The following is a description of a gene set: Human Gene Set: MIR6504_5P species: Homo sapiens Genes predicted to be targets of miRBase v22 microRNA hsa-miR-6504-5p in miRDB v6.0 with MirTarget v4 prediction scores > 80 (high confidence targets). from publication Chen Y, Wang X (PMID 31504780), and this is the list of marker genes: ADD1, AAK1, MSRB2, ZNF12, AP1M1, SLC36A1, TXNIP (thioredoxin interacting protein), FYCO1, ANKRD36, LEMD2, TRAPPC3L, LZTS1, CRIM1, DHCR24, AREL1, HNMT, GALNT10, CNOT10, SLC4A8, EIF5, EDAR, PIP4K2B, PRDM10, BAG4, ATP1B4, CCDC186, PRDM4, CNN3, PTPRT, MRPL52, HEMK1 (HemK methyltransferase family member 1), ZNF850, ZNF782, MECP2, RHOJ, SPRED2, WASHC4, HMOX2, JOSD1, PAX5, NECTIN4, SLC26A1, SAV1, NR4A3, CIMAP2, SLC26A9, PRR15L, PCDH20, TBL1X, CA10, TBC1D2B, UBIAD1, ZNF37A, LDLRAD3, LMX1B, DKK3 (dickkopf WNT signaling pathway inhibitor 3), FZD5, TANC2, MFSD11, ZBTB3, KCNN3, CAPN6, CRY2, ZFAND3, ZNF471, SIX4, IDH2, OGT, CLIP2, SUMF2, REPS2, JPH1, EVC, CSNK1G1, NDST1, SORT1 (NCBI Gene Id 6272), UBE2QL1, TMEM178B, GABRB2, PPP4R2, DDX3Y, MYH9, R3HDM1, KCNK9, RSBN1L, RASSF8, SH3BGRL3, PNO1, ELP5, P2RX7, TBC1D16, PAN3, PIK3R6, ZNF582, CLOCK (clock circadian regulator), RHOF, STK38, SMURF1, HSPB6, DNAJB9, BTBD6, PIK3CB, FBXO17, ZNF74 (zinc finger protein 74), VPS33A, CACHD1, R3HDM4, TFCP2L1, AGO1, TNFRSF25, AP1G1, JADE2, ARHGAP21, SRGAP2, CMTM4, SEZ6, BMF, GPN2, IGFBP5, PHLDB1, GLDN, TCEANC2, PTPRJ, ATP10B, ZNF747, CLIC6, IL1R1, ZNF544, FAM107B, PLXNA2, CLASP2, ODR4, TMEM245, BAIAP2L1, LRGUK, NUDT15 (NCBI Gene Id 55270), VPS4A, PPP3R1, MMD2, APPL2, ADCY1, KLHDC3